Given this list of marker genes Pdk1, Mapk1, Map2k2, Socs1, Irs1, Map2k1, Src, Stat5a, Epo (NCBI Gene Id 13856), Shc1, Epor, Ptpru, Stat5b, Raf1, Rasa1, Jak2, Akt1, Ptprc, Irs2, Stat1, Cish, Stat3, Pik3cg, Sos1, Grb2, Mapk3, here is a description of the gene set: species: Mus musculus Mouse Gene Set: WP_EPO_RECEPTOR_SIGNALING EPO receptor signaling